Given this list of marker genes KAT7, WNT5A, N4BP2L2, TSC22D1, MIR221, EIF2AK2, KITLG, PDCD2, WNT10B, ACE, CEBPA, ATXN1L, WNT1, MIR222, THPO, PIM1, SNAI2, here is a description of the gene set: studied in species Homo sapiens Any process that modulates the frequency, rate or extent of hematopoietic stem cell proliferation. Human Gene Set: GOBP_REGULATION_OF_HEMATOPOIETIC_STEM_CELL_PROLIFERATION